Given this list of marker genes CCDC15, ZMYM2, BEX3, COL4A5, ATF5, SLC46A3, PDCD1 (NCBI Gene Id 56179), SSX2IP, PKN2, SCGB1D1, CETN1, MYO1C, HNRNPA1P37, BMPR1A, HOXA10, ARL6IP4, POLR1G, PLSCR2, HTRA1 (NCBI Gene Id 5654), MPHOSPH8, CENPI, GP6, LINC02637, KPNA4, ACSM3, HOXA6, AQP3, SEL1L3, ASRGL1, RAD50, SPDL1, KYNU, RAB38, CTH (NCBI Gene Id 63046), CNR1, FEM1B, ZBED4, PDE3A, UNKL, SP3, GP5, HSD17B4, OSTF1, TANK, CYP2C18, INSIG1, HSP90AA1, ANKRD42-DT, PBX3, TECTA, CAPRIN2 (NCBI Gene Id 84116), FBXO28, MACIR, LUZP4, SPINK2, RAD1, HFE, MRE11, TNC, HMGN5, RER1, KIF3A, XPC, SELENOP, PI4KB, APTX, TMT1A (NCBI Gene Id 25840), KIF22, FAM131A, SPG7, SH3GL1, TRAF3IP3, RAD51, LIMS1, TNS3, UBR2, H3C10, PLPPR3, IL15, CNOT4, LHFPL6, MTCL1, ALK, CHGB, NFE2L2, GNRHR, SCHIP1 (NCBI Gene Id 29970), HOXB3, TOP1, CHRM5, ZFR2, CACNA1I, HOXB2, ADCY7, PURA, B4GALT4, IP6K1, WRAP73, TRAPPC3, UBE2K, DLC1, TRPM8, HOXA4, HOXB9, MTX2, HUS1, CRP, TXNIP, CAT, COMMD4, HOXA5, ETFDH, SH3BP2, TBC1D17, HMGB1 (NCBI Gene Id 3146), CA7 (carbonic anhydrase 7), TFDP2, ACO1, CA12, WWP1, POLR2C, IQCE, SSX2, HOXA3, KRT10, EMC9, OR7E111P, RBM5, RBM25, MYBPC3, CAVIN2, HOXA7, LEPROT, AK2, MEIS1, TJP2, NFATC1, CLN8, ORC6, ATM, RYBP (NCBI Gene Id 23429), CYB5RL, CEP135, SNX10, GPR21, SERINC3, ADAM12, SOX13, EPHA1, SIX6, SMC4, EML2, MAP3K5, DCUN1D4, NUP43, ST3GAL2, MAGEA9, TNNI3K, HOXB6, RSRC1, MAN2A2, PPARGC1A, PCDHGC3, EDDM3A, CHMP2B, TGS1, GOT1, SC5D, TCP10L3, HOXA9, TRAF6, EXOSC7, ERG28, SLC39A1, DZIP3, VOPP1, PPP1R8, UGGT1, CHST5, GTSE1, CTBP2, HOXA2, PAK1IP1, IDE, ZNF322 (NCBI Gene Id 79692), ATRX, NCAM2, CACNA2D1, HOXB5, DCK, CDK2, CCDC28A, TMCO1, TRIM38, DHFR, PTPN11, RWDD1, SSX4, VCP, H4C3, ZNF768, TVP23B, UGT2B15, CD84, NFE2 (NCBI Gene Id 4778), POU3F1, MAPK10, PDS5B, FKBP1B, GABBR2, SDS, CD47, WNK1, ALX1, CARD9, TM2D3, OGFOD3, CREG1, MSH3, TCEAL9, CSTF1, DPY19L2P2, GPR135, RTL8C, NIPBL, RGSL1, TMEM14A, ITGAX, METAP2, PLCB3, MAP3K7, GPR137B, ZNF780B, WNT5A, GHITM, DST, MCHR1, EXOSC4, RTN2, PKNOX1, EGFL6, FRY, MFAP3, MBNL2, PTCH1, CDK5R1, RAPSN, NEK7, RASSF7, RAP2A, AGBL5, AHI1, PTPN4, TST, CCL23, AP5Z1, GUCA1B, LGR4, ARIH2, CFLAR, ARFIP1, SLIT3, GK, FADS1, DOCK9, here is a description of the gene set: Human Gene Set: MULLIGHAN_NPM1_MUTATED_SIGNATURE_1_UP from publication Mullighan CG, Kennedy A, Zhou X, Radtke I, Phillips LA, Shurtleff SA, Downing JR (PMID 17597811) Somatic mutations in nucleophosmin (NPM1) occur in approximately 35% of adult acute myeloid leukemia (AML). To assess the frequency of NPM1 mutations in pediatric AML, we sequenced NPM1 in the diagnostic blasts from 93 pediatric AML patients. Six cases harbored NPM1 mutations, with each case lacking common cytogenetic abnormalities. To explore the phenotype of the AMLs with NPM1 mutations, gene expression profiles were obtained using Affymetrix U133A microarrays. NPM1 mutations were associated with increased expression of multiple homeobox genes including HOXA9, A10, B2, B6 and MEIS1. As dysregulated homeobox gene expression is also a feature of MLL-rearranged leukemia, the gene expression signatures of NPM1-mutated and MLL-rearranged leukemias were compared. Significant differences were identified between these leukemia subtypes including the expression of different HOX genes, with NPM1-mutated AML showing higher levels of expression of HOXB2, B3, B6 and D4. These results confirm recent reports of perturbed HOX expression in NPM1-mutated adult AML, and provide the first evidence that the NPM1-mutated signature is distinct from MLL-rearranged AML. These findings suggest that mutated NPM1 leads to dysregulated HOX expression via a different mechanism than MLL rearrangement. The 'NPM1-mutated signature 1': genes up-regulated in pediatric AML (acute myeloid leukemia) samples with mutated NPM1 compared to all AML cases with the intact gene. studied in species Homo sapiens